Given this list of marker genes Casp4, here is a description of the gene set: part of: Non-canonical inflammasome activation Reactome Pathway: CASP4 inflammasome assembly species: Mus musculus electronically inferred by orthology from the curated human pathway This event has been computationally inferred from an event that has been demonstrated in another species.<p>The inference is based on the homology mapping from PANTHER. Briefly, reactions for which all involved PhysicalEntities (in input, output and catalyst) have a mapped orthologue/paralogue (for complexes at least 75% of components must have a mapping) are inferred to the other species.